Given this list of marker genes PSMD3, PSMD6, PSMD12, PSMA4, PSMD2, PSMD7, PSMA3, PSMA7, PSMC1, PSME1, PSMB5, PSMD4, PSMD9, PSMD8, PSMA2, PSMC6, PSMB2, PSMC5, PSMB7, PSMD10, PSMD11, PSMD14, PSMD1, PSMA1, PSMB1 (proteasome 20S subunit beta 1), PSMB4, PSMC4, PSMC2, PSMA5, PSMB3, PSMD13, PSMA6, here is a description of the gene set: species: Homo sapiens Genes in the cancer module 28. Human Gene Set: MODULE_28